The following is a description of a gene set: Comprehensive identification of all functional elements encoded in the human genome is a fundamental need in biomedical research. Here, we present a comparative analysis of the human, mouse, rat and dog genomes to create a systematic catalogue of common regulatory motifs in promoters and 3' untranslated regions (3' UTRs). The promoter analysis yields 174 candidate motifs, including most previously known transcription-factor binding sites and 105 new motifs. The 3'-UTR analysis yields 106 motifs likely to be involved in post-transcriptional regulation. Nearly one-half are associated with microRNAs (miRNAs), leading to the discovery of many new miRNA genes and their likely target genes. Our results suggest that previous estimates of the number of human miRNA genes were low, and that miRNAs regulate at least 20% of human genes. The overall results provide a systematic view of gene regulation in the human, which will be refined as additional mammalian genomes become available. Genes having at least one occurrence of the highly conserved motif M1 RCGCANGCGY in the regions spanning 4 kb centered on their transcription starting sites. This matches the NRF1 transcription factor binding site V$NRF1_Q6 (v7.4 TRANSFAC). Human Gene Set: RCGCANGCGY_NRF1_Q6 from publication Xie X, Lu J, Kulbokas EJ, Golub TR, Mootha V, Lindblad-Toh K, Lander ES, Kellis M (PMID 15735639) species: Homo sapiens, and this is the list of marker genes: WDR12, U2AF1L4, RTCB, GET1, RASA1, TDG, PAIP2, PNRC1, L1CAM, DNAJB12, NR2C2AP, ATAD3A, RNF149, ARMC6, GTF2A1, DDX3X, ARFGAP3, YIPF2, OSTC, CHL1, TRAPPC3, RABGGTB, PRDX4, RAB35, NOB1, SMARCB1, MAP4K1, QPCTL, HSPE1 (heat shock protein family E (Hsp10) member 1), C22orf23, ZNF638, ELP5, SND1, MOK, CCS, PLOD3, UROS (NCBI Gene Id 7390), INTS11, AGFG2, SENP7, PDLIM7, CACUL1, POP7, MRPS9, TCF25, AKAP8, VASH1, CNP, SENP1, UBE2M, TOMM7, EXOC8, ARSK, DYNLRB2, TUBGCP4, FCHSD2, NEK8, B9D2, RHBDD3, SRRM1, SRPK1, HDX, SMARCA5, MAPKAP1, C2orf15, EMC10, SESN1, SLC25A3, PCCB, PALS1, CNIH1, JAG1, TDP2, GNG10, SAMD8, CRTC1, AATF, MRPL49, KDM5C, ARID4A, VPS13C, DNAJC11, COX7A2L (NCBI Gene Id 9167), CIRBP, TIMM29, XRCC1, DIDO1, SAE1, HSDL1, NDUFA8, EBP, WDFY2, RTBDN (NCBI Gene Id 83546), PPP1R10, HTN1, NAPG, LSM2, STAG1, ZSCAN29, TSSK6, NUDT11, PFDN1, RMDN1, BASP1, CCDC93, STK38, GOLGA4, UQCRC1, FAM13B, SPRTN, CKS1B, MFSD8, NFYA, RNF123, RFXAP, ZMYM2, TDP1, ZNF12, CNTROB, DPYSL2, ERRFI1, SLC25A51, CCDC106, NAE1, ZNF576, PHF12, H1-2, PSD, PGAP1, SMC6, ABHD14B, CCDC171, ABHD10, REEP4, MLH1, CCDC12, RASSF1, WNT5A, UBAC2, GDPD1, MRPS18B, ARMC2, POLA1, GABRB2, MLX, ILF3-DT, CSNK2B, HSDL2, FYTTD1, TAOK2, PCGF6, ZMYM6, KLHL10, INTS7, CHMP2B, MED11, DAZAP1, FUS, ALG5, ACTB, SF1, CDK16, RALBP1, CHCHD4 (coiled-coil-helix-coiled-coil-helix domain containing 4), PIGV, LIN37, GMNN, IPO9, RAD23B, EID2, TUBG2, TBC1D17 (NCBI Gene Id 79735), ERCC6, RDH10, TMEM161B, CNOT4, OARD1, MAZ, UGGT2, PITHD1, TIGAR, RAB10, WDR35, DAD1, AOPEP, LSM1, DNAJB9, CYP2R1, CLOCK, CCT3, ZNF692, CCDC127, ZNF2, TIMM21, EIF2S1, TMF1, SMC4, TTLL4, SPOP, ILVBL, TMEM38B, MIER1, ITCH, MSH4, RAB1B, TULP3, TSC22D1, FBXO15, SBDS, LIG3, KDM3A, ATP5F1D, TSEN54, CDK19, ASB8 (NCBI Gene Id 79076), GTPBP10, SDR39U1, PRPF6, MINK1, CHERP, AKT2, INTS2, EID1, FXR2, YIPF5, NPAT, GEMIN4, CRMP1, CDC5L, RBM4B, TRIM28, TRAPPC1, WDR44, CAPN7, ZNF644, RSU1, AP1M1, TMEM69, MED26, NDN, PGRMC2 (progesterone receptor membrane component 2), PIGF, IL4I1, BCL7A, TEX264, HERC4, HSPB9, RRP9, MORF4L2, HSPD1, MAP2K2, HOOK3, OGA, MCM4, EIF3K, PRPF3, CSTF1, ALG6, HMMR, EXOG, EXOSC8, RTN3, GRB2 (growth factor receptor bound protein 2), ICMT, FTSJ3, NF1, STAG2, MRPL30 (mitochondrial ribosomal protein L30), PACRG, GATD3, ATP5MJ, FOS, OVOL1, LRRIQ3, KAT7, KDM1A, GSS (glutathione synthetase), SBF2, SMARCD3, GEN1, PDXDC1, INTS3, FAM133B, SLC35D1, C14orf178, TMTC2, CFAP52, HNRNPH1, NPRL2, AFG2B, RNF24, AKR7A2, RABGAP1, PREB, CACNA1B, SHMT2, VPS26B, SPRY4, ZBTB17, CDS2, PTMA, DNAJA3, MLST8, TMEM30A, SMG6, SLC39A7, SRRM2, BAG6, ATP5MC2, NAPB, MRPL45, EID2B, GTF2E2, DDX39B, RABIF, MZT2B, ZNF322, SLC6A7, DPY30, SUGP2 (NCBI Gene Id 10147), TMEM187, INO80C, CBR3, PRKAR2A, PABPC1, SRSF7, ABHD5, NDUFAF5, ZCWPW1, ZNF286A, PLEKHA1, NUDCD2, NUDT4, TMED4, POLR2B, FHOD1, CEP19, SLC9A5, DDIT3, ZC3H8, POMT1, ATP5PO, CYP7B1, NFAT5, SRSF9, NPM1 (NCBI Gene Id 4869), PHKG2, SRSF1, BCDIN3D, NT5C3B, GEMIN2, AP1S1, TMEM185A, IFT80, ANP32A, MST1, LIPT2-AS1, EMSY, THAP5, CCAR1, RNF111, OMA1, RNF170 (NCBI Gene Id 96586), RTKN2, CBLL1, CFAP44, RPRD2 (NCBI Gene Id 23248), GTF2A1L, TXNDC9, TMEM184B, CCDC47, DISP2, BANP, VSNL1, HNRNPDL, DSN1, ILF3, SMAP2, MEF2B, UQCC2, TMOD3, DHX9, PALB2, ABHD15, RXRB, CBX5, CKLF, APBB3, MAPT, POLR2A, GIT2, PRKDC, LMO3, DAW1, AIFM1, FPGT, CFAP20DC, LRCH3, RHPN1, EDEM3, CRIPT, PTPN2, USF2, FAM222B, PPP1R12A, CIPC, EGLN2, ZNF646 (NCBI Gene Id 9726), RALGAPB, CCNA2, ZBTB4, SDCCAG8, C6orf136 (chromosome 6 open reading frame 136), CISD1, CNKSR2, ZC3H14, CBFB, CASP2, EXOSC2, U2AF2, BAG4, CMTR1, MFSD9, USO1, FADD, CLPX, WDR20, PTGR2, RBBP8, LENG8, HIGD2A, KANSL1L, HIBADH, DCTN5 (dynactin subunit 5), MPDU1, ZMYM4, ATP5MG, SON, ITGB1BP1 (integrin subunit beta 1 binding protein 1), EWSR1, SNRNP70, PHF23, RPS16, RNF216, ARRDC3, ARAF, ZNF281 (zinc finger protein 281), CBY1, PSMA4, CTCF, WAC, RTCA, PSENEN, TRIM37, ESF1, CARNMT1, JAK2, KANSL3, UBA52, NUBP1, SOCS4, PCGF1, DRG1, UBE4A, RAVER1, C21orf58, CHMP5, WIPI2, DENND6A, SIRT6, EED, GABRB1, ABI1, KDM4C, SRR, FKBP2, SCAMP3, TUBA1B, ZFP91, TRMT11, PDCD2L, FAM219B, UBE2K, DVL2, PARP3, FOXA3, NCAPH, FMR1, BSN, KIF3A, RWDD1, SYMPK, TSGA10, ZCCHC7, FOXO4, SAMD10, CNOT9, CCNF, SNAPC1, SET, ARPC2, CIRBP-AS1, PDCL3, SLC4A2, AURKA, MBD3, STX8, FUT11, BRK1, NR0B1 (NCBI Gene Id 8238), AIMP2, JAGN1, HNRNPA1, PEX16, SCAMP2, TMED5, MFSD13A, IRF2BPL, ZBTB5, CARF, ICMT-DT, CPSF3, PGLS, PRKN, ZC2HC1C, POLR2F, RHPN1-AS1, PIAS4, AP2A1, ISCU, MTCH2, CCDC150, UBE2D3, KAT2A, SIX5, MAP3K11, FAM219A, GOPC, CNOT1, NNAT, INTS5, TOP1, MRTFB, CD320, ANAPC16, TBCCD1, GIN1, ARF4, FASTKD2, CFAP418, MRPL14, RPS29, MTFR1, RFXANK, TSACC, RPL7, AP1G2, MORC3, NAA35, PPP4R4, CCDC181, NUDT10, CXCR4, ZFAND3, LETMD1, EIF1AX, DYNLT1, ONECUT1, SPINT2, HAPSTR1, CSDE1, MAP2K7, RANBP3 (RAN binding protein 3, NCBI Gene Id 8498), CHMP3 (NCBI Gene Id 51652), NDUFS6, GPATCH11, PPME1, CNTNAP1, SMAD5, PRRG1, TENT2, DDX42, EIF5B, ING2, PHAF1, PMS2, GPR85, POU2F1, DUSP6, DENND2B, ALKBH5, GART, ACIN1, ARPC5, SLC35A4, SSH2, STT3B, DNAJA1, RBM12, HSPA4L, SNHG29, SNRPD2, MAGIX, MOCS2, ABHD14A, FMC1, RUNX1T1, ELP6, DNAAF1, NEUROD1, ASZ1, CCDC87, ZMYND10, C14orf119, COQ3, PLK4, PARS2, SDHA, KDM2A, STIM2, SMC5, KIF5B, POLA2, MCRS1, PPP2CA, SAYSD1, TMEM106C, LYST, CPSF4, RAB18, TIA1, ZNF770, HNRNPL, CRY1, CLEC18C, MAGEE1, VAT1, DCTN4, SMIM11, SMPD4, DFFB, MITD1, VAV3, UQCR10, BAD (BCL2 associated agonist of cell death), ASRGL1, XPO5, CYB561D2, DCAF8, UTP18, FBXO5, MORN5, POLH, MAD2L1, CCT5, NDUFA13 (NADH:ubiquinone oxidoreductase subunit A13), POLR2H, TNKS2, EIF2S2, EIF1, BCLAF1, KIN, ACOT13, TBC1D32, IFT27, NCAPD3, SAMTOR (NCBI Gene Id 154743), GABPB2, C9orf163, MACROD2, AGO1, EIF3A, TMEM43, PAQR4, TCTA, GRK5, SHC1, TSEN2 (NCBI Gene Id 80756), BTBD8, PARP6, NOP16, USP37, ZDHHC12, KIFAP3, TMEM106B, FAM98A, TP53I13, PSMC5, CDK10, DNAI1 (NCBI Gene Id 3393), EDEM2, GTF3C1, MAPK7, CCR10, SSR4 (signal sequence receptor subunit 4), IWS1, RPL5, STX12, SNW1, BRD2, RSPH14, CDV3, SERP1, PDE7A, STK31, PSPC1, TRIM39, ACTR1A, DNM3, ATF5, PSTK, PTGES3, SLC16A13, OAZ2, EIF2A, CASK, ZNF454, MDH1B, SLC7A10, WDTC1 (NCBI Gene Id 23038), ZNHIT1, ZGRF1, MEPCE, CCDC107, B9D1, RAD21, CEP85, MRPL36, CKS2, SNURF, CCNJL, CBR1, EPM2AIP1, RAB3IP, SELENOT, TMEM143, EXOSC5, ASIC1, SGF29, COX6C, TYW1, RETREG2, ABHD18, OTUD6B, ATP6V1D, HILPDA, KPNA1, ZFYVE16, PEX11G, VCPIP1, SLC2A4, CTSF (NCBI Gene Id 8722), ERG28, BLOC1S2, RILPL1, RBBP7, NT5DC2, ARF6, GTF3C2, SELENOI, PPP1CB, NCBP1, NUP62, KCTD13 (potassium channel tetramerization domain containing 13), TBC1D15, PIGX, TAF7, ERGIC3, PHLPP1, WNK1, ZNF668, MIB1, SART3, IDH3G, RNF8, THAP11, P4HA1, IPO11, ATPSCKMT, BCCIP, RNF40, RBM14, FAM120C, PCNA (NCBI Gene Id 5111), NDUFA5 (NADH:ubiquinone oxidoreductase subunit A5), LRP1, UXS1, MAGEE2, ATP5MC3, PABIR2, AKIRIN2, ZNF382, GJB1, SGCB, NBEA, HINT1, CPNE1 (copine 1), MRPL22, SPTY2D1, GPC2, OSER1, PDCD6IP, DENND5A, SZRD1, PPM1A, UCHL3, CENPO, PACC1, GPANK1, TIGD6, EHD1 (EH domain containing 1), RHOA (ras homolog family member A), AKIP1, CNPPD1, ARRB2, CFL1, TXNL1, TECR, PPP1R12B, NRGN, TMEM255A, TDRD1, ABCC5, SNRPN (small nuclear ribonucleoprotein polypeptide N), NUP107, PPP1R15B, ABCF3, DPF2 (NCBI Gene Id 5977), TRAF3IP1, PCSK1N, PHF1, SEH1L, TMEM179, CDKN2B, MTFMT, SLC46A1, C2CD6, SLC66A1, CENPI, C15orf40, TOPORS, MKNK1, PPM1D, PDRG1 (p53 and DNA damage regulated 1), SEC24C, PTCD1, NR1D1, PIAS1, ZNF653, CASKIN2, RGL1, HACD3, BCKDHA, SUFU, ATM, SAFB, ATP2C1, DNAI4, FUT8, YEATS4, CLGN, LRP2BP, NOA1, COG6, SKIC3, CLCN2, ANAPC15, SLC35B3, PKD2L2, ATF7IP, MXD3, SORCS3, ADAM10, CIMIP6 (ciliary microtubule inner protein 6), PAXBP1, MAPRE3, MLH3, ZNF428, TUBG1, WDHD1, EIF5A, PRR16, NAA15, STAG3, KRCC1, AKAP13, CCDC97, MAGED1, TBC1D5 (TBC1 domain family member 5), EFCAB11, PAGR1, PIM3, EIF2B3, PCIF1, TSTD2, MAX, SNAP29, UPF2, LAMTOR3, TMEM108, BAG1, TMEM115, GTF2F1, SLC25A31, ABCB6, GOLGA1, MECP2, SIKE1, MTPN, AKT1S1, FGF12, ATP5F1C, NR2C1, MTRFR, NAA25, PABIR1, ATP6V0D1, CAPNS1, MRPL17, KBTBD2, SLC3A2, RNF19B, PCNT, STARD10, NDRG3, RPS23, CORT, SP8, CHMP2A, NPDC1, SRSF2, PINK1, FARSB, CTDNEP1, RETREG3, SAP18, BMPR2, TOLLIP, MED25, ESCO1, SYNGR4, CCNI, DNMT1, PCYT2, METTL22, ELOVL4, MAGED2, TIAL1, ESRP2